The following is a description of a gene set: Human Gene Set: GOBP_FOREBRAIN_REGIONALIZATION The regionalization process resulting in the creation of areas within the forebrain that will direct the behavior of cell migration in differentiation as the forebrain develops. species: Homo sapiens, and this is the list of marker genes: GSX2, PGAP1, LHX2, SHH, EMX1, TRA2B, SIX3, FEZF1, EOMES, GLI3, WNT2B, WNT1 (Wnt family member 1), BMP2, ADGRG1, NKX2-1, PAX6, BMP4, EMX2, FGF8, TTC21B, LHX1, WNT7B, DMRTA2, FEZF2